Given this list of marker genes NFIB, DNAJB1, TAF1, ZNF451, PASD1, WWP2, SNIP1, ANXA4, TCF23, MDFI, TRIB1, ELK1, ID1, TAF3, HSPA1A, HES6, SMAD6, ID2, CTNNBIP1, ID4, NR0B2, SIRT1, SRI, PKD1, PURA, TFDP3, PKD2, SIN3A, NFKBIL1, NKX3-1, LEF1, NCOA2, NFKBIA, TRAPPC2B, ID3, KEAP1, HEXIM1 (NCBI Gene Id 10614), SMAD7, LYAR, DDIT3 (NCBI Gene Id 92982), DAXX (NCBI Gene Id 1616), here is a description of the gene set: A molecular function regulator that inhibits the activity of a transcription regulator via direct binding and/or post-translational modification. species: Homo sapiens Human Gene Set: GOMF_TRANSCRIPTION_REGULATOR_INHIBITOR_ACTIVITY